The following is a description of a gene set: Mouse Gene Set: GOBP_DEFINITIVE_HEMOPOIESIS studied in species Mus musculus A second wave of blood cell production that, in vertebrates, generates long-term hemopoietic stem cells that continuously provide erythroid, myeloid and lymphoid lineages throughout adulthood., and this is the list of marker genes: Smarca4, Adar, Hoxb3, Sp1, Kmt2a, Tal1, Mpl, Runx1, Tgfbr3, Cdk5rap3, Ncor1, Senp1, Sp3, Hoxb4, Zfp36l2, Cbfb, Bcr, Gata1, Meis1, Mfap5, Lyl1, Zfpm1, Hoxa9, Gata2, Rbfox2